Given this list of marker genes FBXO32, ESR2, VEGFA, UPF1, PPARGC1A, TRIM63, MYF5, CDKN1A, H3Y1, RET, ADRB2, H3Y2, MYOD1, MYC, PAX7, MYOG, DUX4, EP300, here is a description of the gene set: Pathophysiological roles of DUX4 in FSHD1 studied in species Homo sapiens Human Gene Set: WP_PATHOPHYSIOLOGICAL_ROLES_OF_DUX4_IN_FSHD1